Given this list of marker genes Pigz, Lpp, Cadm2, Adcy3, Cdk8, Vip, Rnf43, Rufy3, Stradb, Ugt3a2 (UDP glycosyltransferases 3 family, polypeptide A2), Atp6v0e, Mapk6, Igf2bp3, Vps26b, Cntnap2, Selenof, Gk (glycerol kinase), Ttpa, Gclc, Heatr5a (HEAT repeat containing 5A), Srbd1, Zyg11b, Cdv3, Pde4b, Fgf12, Pramel5, Ap1g1, Sval1, Tmem154, Fam107b, B230219D22Rik, Pik3c2b, Psma2, Gli2, Osbpl8, Zfp770, Zfp58, Kdelr1, Hipk1, Rgs13, Cd24a, Prkg1, Tnmd, Rb1, Pate12, Clasp1, Nsmaf, Avpr1a, Klhdc4, Frmd5, Ebf1, Cldn4, Lrrc39, Ranbp9, Thoc2, Rapgef2, Usp37, Mtss1, Acbd5, Nova2, Serpinb11, Tagln2, Cd22, Slc17a3, Pdcd4, Ankrd27, Csnk1d, Ppfia1, Ifit1bl2, Stxbp5l, Yy2, Yrdc, Bptf, Zkscan3, Pls1, Tfpi, Tmem47, here is a description of the gene set: Genes predicted to be targets of miRBase v22 microRNA mmu_miR_7038_5p in miRDB v6.0 with MirTarget v4 prediction scores > 80 (high confidence targets). Mouse Gene Set: MIR_7038_5P from publication Chen Y, Wang X (PMID 31504780) studied in species Mus musculus